Given this list of marker genes ING5, RIOX1, POMGNT2, TIMM10, LTF, TCN2, ZNF496, TENT5A, RNF169, HLF, B3GAT1, CHCHD7, TLR4, SLC25A28, PORCN, SH3GL2, TMEM191C, SLC22A3, SPRR3, ETV6, MAPK1, C8orf58, FHIP1B, SELP, CA9, ALS2 (alsin Rho guanine nucleotide exchange factor ALS2), COL4A3 (NCBI Gene Id 200750), HES3, TCEAL8, HEBP1, RNF113A, TBC1D8B, ALDH1L1, FLNB, AREL1, PSD3, GRB10, SMIM17, ABCD3, TCAF1, PRXL2A, SCMH1, RALGAPA1, AZI2, RNF144A, GALC, RIGI, CYP4A11, PML, FAM171A1, TMEM98, TMBIM6, TMEM258, ORC3, SLC24A3, CABP7, NAALADL2, SPATA4 (spermatogenesis associated 4), PDZD8, DGAT1, KIAA0040, SLC29A2, FBH1, FBXO16, PDCD4, HADH, MLLT3, STK16, RGS14, NEU1, ABHD14B, PTGR1, DEF8 (differentially expressed in FDCP 8 homolog), COPA, ZCRB1, CYP11A1, NFIA, PRAM1, GLA, GAS2L1, LMO2, WDR48, STMP1, TMEM18, C18orf32, ZMPSTE24, NBEAL2, SON, COPS7A, CA2, SLCO3A1, ZNF438, SH2D4A, MOGAT2, PEX11A, ATRN, VIP, CXXC5, STK26, ZPBP, SPAG4, PSEN2, PKD2, RAB34, GID4, C10orf88, P3H3, TST, ATP10D, CHRNB4, TSPOAP1, SPO11, MARVELD2, PRR22, IL15, PROM1, CSTB, VSIG10L, FRMD4A, TMX4, PCDHB1, LIMA1, CPNE4, THRSP, FER, CD274, CCL20, ABCA7, SUSD1, TSLP, FXYD2, ERG, HDC, ICA1, CCDC88C, SLC27A4, SULT1B1, PPIC, CD79A, LTBP3 (NCBI Gene Id 4054), F7, LONRF1 (LON peptidase N-terminal domain and ring finger 1), BOLA2, INPP5E, GSR, TRIP6, FRA10AC1, HGF, USP49, SNAPC4, PXK, ANXA9, ZNF330, PXYLP1, EIF1AY, PPM1H, UQCC6, SCARF1, TIGD2, OTOS, CCDC80, SRPRA, NUDT13, PADI1, PCDH15, ADGRG1, DTD1, VSNL1, HSD11B1, HTRA2, MRGBP (MRG domain binding protein), HSD17B11, CDK5R1, L3HYPDH, TRABD2B (NCBI Gene Id 388630), LIG4, MRPL36, IGF2BP1, RIDA (NCBI Gene Id 137671), MPV17, MFAP3L, SLC12A3, GRM5, GGA1, DRC3, SYNE4, GTF2IRD2, MSRA, TRIM6, TTC39B, SDSL, CERS4, PRKAR2B, PIP5K1B, QSOX1, CA1, METTL6, ZSWIM3, MB, SMPX, here is a description of the gene set: studied in species Homo sapiens from publication Szanto A, Balint BL, Nagy ZS, Barta E, Dezso B, Pap A, Szeles L, Poliska S, Oros M, Evans RM, Barak Y, Schwabe J, Nagy L (PMID 21093321) Genes up-regulated in bone marrow-derived macrophages with PPARG knockout: control versus IL4 and rosiglitazone. Conditional macrophage-specific PPARg knockout mice were generated on C57Bl/6 background by breeding PPARg fl/- (one allele is floxed, the other is null) and lysozyme Cre transgenic mice. PPARg and IL-4 signaling was analyzed on bone marrow-derived macrophages. Bone marrow of 3 mice per group was isolated and differentiated to macrophages with M-CSF (20 ng/ml). 20 ng/ml IL-4 was used to induce alternative macrophage activation and 1 uM Rosiglitazone (RSG) was used to activate PPARg. From each mouse 4 samples were generated: 1. M-CSF, 2. M-CSF+RSG, 3. IL-4 and 4. IL-4+RSG. All compounds were added throughout the whole differentiation process, and fresh media was added every other day. Control cells were treated with vehicle (DMSO:ethanol). After 10 days, RNA was isolated and gene expression profiles were analyzed using Mouse Genome 430 2.0 microarrays from Affymetrix. Human Gene Set: GSE25123_CTRL_VS_IL4_AND_ROSIGLITAZONE_STIM_PPARG_KO_MACROPHAGE_UP